Given this list of marker genes ARRDC4, CHST7, RAB11A, SLC37A3, INO80D, PLGRKT, TYK2, AGFG1, PRMT9, BTBD1, NICOL1, CSNK2B, ATP6V0D1, MTERF1, PRRC1, MAP2K7, UPF3A, ARHGEF4 (Rho guanine nucleotide exchange factor 4), PITPNM1, PPP2R2A, SPIDR, ATP6V1H, RAPGEF1, HSPA2, ARAP1, PRKAR2A, SAMD10, THAP11, MCEE, ST13, SELENOP, YAF2, MCMBP, NXPE3, CHAC1, CDK13, PACC1, CCDC62, TRAPPC6A, ABHD11, KRT80, CDC42EP2, CLTA, TMEM30A, OSBPL7, KMT2D, GPR108, DHX58, NEDD8, TRMT10B, ZCCHC8, RASGRP2, TMEM61, PARG, POLR1H, SPNS3, MIEF2, NKIRAS2, GSTM4, DHX36, ABCD1, WASHC4, SGTA, SLFN13, RFX5, PGAP6, L1CAM, REXO4, TRIM14, ARHGDIA, HERPUD2, IPO8, RARS1, RHOH, UBXN4, PSMB10, ATP5F1E, PRKRA, RPS6KA3, CYP51A1, ZNF638, NLN, CBX8, APLNR, SHARPIN, LIG4, FARP1, ATP13A2, RNF138 (NCBI Gene Id 51444), RTP4, SPG11, DNAJC3, SAR1A, RNF31, DCTN6, CSAD, CCDC71, TMED3, SMIM15, TLX1, ATN1, ATP10A, PDE4B, SERHL2, NFAM1, PRPSAP1, KMT5B, ANP32A, STXBP3, SETDB1, IRF2, NDUFS4, RAB24, MED4, DHCR7, GMDS, DPM2, GIT2, CDKL4, WBP1L, ITFG1, NUDT18, ZNRF1, NAA35, SNF8, SNAPIN, UBR5 (ubiquitin protein ligase E3 component n-recognin 5), ERBIN, APPBP2, HNRNPA0, AAGAB, GOT2, SBNO1, TPD52L2, PTPN12, ARF6, HOMEZ, CD300LD, TRIM41, KLC1, PNKD, TUG1, NCOA6, NFKBIL1, SMAD2, TLR1 (NCBI Gene Id 7887), NFKBIZ, FAM120B, NDUFS6, PLCB2, SNX9, PLEKHG2, NFIC, RHOT1, VPS13D, ING1, PNPLA2, PLCB3 (phospholipase C beta 3), WDR77, EPB41L2, IKBIP (NCBI Gene Id 387877), IKBKB, PPHLN1, NAB1 (NGFI-A binding protein 1), RNF19B, TIMM8B, NAA10, CORO1C, SLC35A3, PLPP6, TMEM223, TMEM168, ZNF319, KMT2A, PHF23, RIOX2, BLCAP, FBXO11, MAGED1, COP1, ERLIN1, SEC22B, TNFRSF18, EBP, CLUAP1 (clusterin associated protein 1), ZNF24, ATPAF1, EXTL2, KPNA4, CSNK1G1 (casein kinase 1 gamma 1), HDAC5, NRBF2, CNOT8, SLC35C2, DPP3, PURB, ZNF467, LRP10, ERP44, HOPX, here is a description of the gene set: Genes down-regulated in comparison of erythroblasts versus neutrophils. Each fraction of mouse hematopoietic cells was purified by cell sorting from bone marrow of 8-week-old C57BL/6 mice, and its gene expression was analyzed. studied in species Homo sapiens from publication Konuma T, Nakamura S, Miyagi S, Negishi M, Chiba T, Oguro H, Yuan J, Mochizuki-Kashio M, Ichikawa H, Miyoshi H, Vidal M, Iwama A (PMID 21540074) Human Gene Set: GSE27786_ERYTHROBLAST_VS_NEUTROPHIL_DN